The following is a description of a gene set: The chemical reactions and pathways resulting in the formation of a medium-chain fatty acid. A medium-chain fatty acid has an aliphatic tail containing 6 to 12 carbons. species: Mus musculus Mouse Gene Set: GOBP_MEDIUM_CHAIN_FATTY_ACID_BIOSYNTHETIC_PROCESS, and this is the list of marker genes: Acot7, Oxsm, Abhd3, Abhd1, Olah, Abhd2